The following is a description of a gene set: Human Gene Set: KYNG_ENVIRONMENTAL_STRESS_RESPONSE_NOT_BY_UV_IN_WS The accumulation of DNA damage and mutations is considered a major cause of cancer and aging. While it is known that DNA damage can affect changes in gene expression, transcriptional regulation after DNA damage is poorly understood. We characterized the expression of genes in human primary fibroblasts after exposure to three different kinds of cellular stress that introduces DNA damage: 4-nitroquinoline-1-oxide (4NQO), gamma-irradiation, or UV-irradiation. Each type of stress elicited damage specific gene expression changes of up to 10-fold. A total of genes had similar changes in expression of 3-40-fold after all three kinds of stress. We examined transcription in cells from young and old individuals and from patients with Werner syndrome (WS), a segmental progeroid condition with a high incidence of cancer, and found various age-associated transcriptional changes depending upon the type of cellular stress. Compared to young individuals, both WS and old individuals had similarly aberrant transcriptional responses to gamma- and UV-irradiation, suggesting a role for Werner protein in stress-induced gene expression. Our results suggest that aberrant DNA damage-induced gene regulation may contribute to the aging process and the premature aging in WS. studied in species Homo sapiens Human environmental stress response genes not changed in primary fibroblasts from patients with Warner syndrom (WS). from publication Kyng KJ, May A, Stevnsner T, Becker KG, Kølvrå S, Bohr VA (PMID 15897889), and this is the list of marker genes: ARPC1B (actin related protein 2/3 complex subunit 1B), SLC30A5, SOD1, RHOB, LCK, TAF1C, NDRG1, TP53I11, HGF, ZNF507 (zinc finger protein 507), HLA-DQA1, SOX7